Given this list of marker genes Ring1 (ring finger protein 1), Ube2srt, Anapc15, Anapc11, Anapc1, Cbx7, Cbx8, Anapc13, Rnf2, Anapc16, Pcgf3, Anapc10, Brcc3dc, Cdc26, Rbx1, Bard1, Phc1, Anapc2, Samd7, Pcgf6, Cdc20b, Cdc23, Brcc3, Samd11, Ube2s, Anapc15-ps, Babam2, Bcor, Brca2, Bmi1, Fzr1, Pcgf2, Cbx4, Phc2, Cdc20, Anapc4, Brca1, Phc3, Anapc7, Rad51, Pcgf5, Cbx2, Cbx6, Ube2c, Anapc5, Cdc27, Mad2l2, Aurkaip1, Pcgf1, Cdc16, here is a description of the gene set: A ubiquitin ligase complex found in the nucleus. Mouse Gene Set: GOCC_NUCLEAR_UBIQUITIN_LIGASE_COMPLEX species: Mus musculus